Given this list of marker genes MTHFD1, CTH, ENSG00000274276, CBS, MPST, here is a description of the gene set: Human Gene Set: GOBP_TRANSSULFURATION studied in species Homo sapiens The interconversion of homocysteine and cysteine via cystathionine. In contrast with enteric bacteria and mammals, Saccharomyces cerevisiae has two transsulfuration pathways employing two separate sets of enzymes.